Given this list of marker genes Pml, Scrib, Eif2s1, Eif4ebp1, Eif4ebp2, Gigyf2, Fmr1, Larp1, Rpl13a, Bank1, Paip2 (NCBI Gene Id 67869), Paip2b, Rbm4, Eif4ebp3, Bc1, Eif4e2, Ago2, Eif2ak4, Zfp598 (zinc finger protein 598), Tpr, here is a description of the gene set: Mouse Gene Set: GOBP_NEGATIVE_REGULATION_OF_TRANSLATIONAL_INITIATION studied in species Mus musculus Any process that stops, prevents, or reduces the frequency, rate or extent of translational initiation.